Given this list of marker genes PEX2, ANKRD11, DSE, TOMM7 (NCBI Gene Id 54543), RUNX2, ATP7A, GH1, CTSK, here is a description of the gene set: Persistent open anterior fontanelle Human Gene Set: HP_PERSISTENT_OPEN_ANTERIOR_FONTANELLE The anterior fontanelle generally ossifies by around the 18th month of life. A persistent open anterior fontanelle is diagnosed if closure is delayed beyond this age. studied in species Homo sapiens